The following is a description of a gene set: UCH proteinases studied in species Mus musculus Mouse Gene Set: REACTOME_UCH_PROTEINASES, and this is the list of marker genes: Psmd12, H2ac8, H2ac18, Psma4, Ogt, Nedd8, Yy1 (NCBI Gene Id 22632), Kdm1b, Uchl1, Nfrkb, Senp8, Ino80c, Psmb4, H2ac12, Mbd6, H2ac25, Actb, Psmb3, Ubc, Ino80e, Bap1, H2ac7, Mcrs1, Psmc4, Foxk2, Psma1, Actl6a, Ruvbl1, Asxl1, Bard1, Adrm1, H2ac1, Psmd8, Hcfc1, Psmd14, Psmd3, H2ac15, Psmd13, H2ac24, H2ac13, Psma5, H2ac4, Psmc2, H2ac22, Uchl3, Psmb2, Psmd7, Ubb, Psmb7, Psmb5, H2ac21, Psma7, Psmd1, Psmc3, Psma6, Actr5, Psma3, Tfpt, Psmd6, Ino80b, H2ac10, Psmd2, H2ac6, Psma2, Uba52, Psmb1, Psmc1, H2ac23, Ino80, H2ac11, Rps27a, Actr8, Psmc6, Psmd11, H2aj, H2ac19, Asxl2, H2ac20, Uba52rt, Psmc5, Psmb6, Ino80d, Foxk1, Mbd5, Uchl5